The following is a description of a gene set: species: Mus musculus Mouse Gene Set: GOBP_VENTRICULAR_CARDIAC_MUSCLE_CELL_MEMBRANE_REPOLARIZATION The process in which ions are transported across the plasma membrane of a ventricular cardiac muscle cell such that the membrane potential changes in the repolarizing direction, toward the steady state potential. For example, the repolarization during an action potential is from a positive membrane potential towards a negative resting potential., and this is the list of marker genes: Kcne5, Kcne3, Zmpste24, Scn4b, Kcnh2, Dlg1, Scn1b, Kcnj8, Kcnq1, Gja1, Kcne4, Rnf207, Kcne1, Snta1, Kcnd3, Scn2b, Ank2, Akap9, Scn5a, Wdr1, Cacna2d1, Cav3, Gja5, Kcnh6, Nos1ap, Kcne2